Given this list of marker genes SLC4A10, CLN3, PPFIA3, KMT2A, SHISA6, GRIK2, SLC8A2, SYP, SYNGR1, SHISA8, SHISA9, GSG1L, RAB3A, SYAP1, SYT4, RAB3GAP1, here is a description of the gene set: Human Gene Set: GOBP_REGULATION_OF_SHORT_TERM_NEURONAL_SYNAPTIC_PLASTICITY A process that modulates short-term neuronal synaptic plasticity, the ability of neuronal synapses to change in the short-term as circumstances require. Short-term neuronal synaptic plasticity generally involves increasing or decreasing synaptic sensitivity. studied in species Homo sapiens